Given this list of marker genes AFAP1L1, BPIFC, EPX, SGMS2, ABCG1 (NCBI Gene Id 9619), NRG1, RALB, TCN2, PLCG2, TET2, PELI2, ERO1B, GZMH, TTPA, LAPTM5 (NCBI Gene Id 7805), RAB11FIP5, NAV2, RAB27B, ARID5A, HPGD, DEPP1 (DEPP autophagy regulator 1), GFI1, EMP1, IL21R, TIFAB, MYO7A, HP, PRG3, F2RL3, CCDC125, SLC16A9, GPR15LG, SEPTIN6, CEMIP2, OLR1, S100A11, UNC93B1, STOX2, SLC7A6, TF, PKD1L3, TMEM141, C17orf50, GBX2, GOPC, MS4A3, ELANE, MAP3K15, VPREB3, FCGR2A, FFAR2, STARD8, TLR12P, CD48, P2RX7, CUEDC1, TCEA2, TEK, TMEM144, CLEC5A, PLD4, SUN2, CXCR6, CEBPE, CPNE3, SLC32A1, GCHFR, MCUB, PRODH, LDHB, RNASE2, ATRNL1, HSD17B1, ARMCX4 (armadillo repeat containing X-linked 4), MTF2, ENDOU, ELOVL7, F10, CASP1, KLHL5, TMEM119, VAT1, SPNS3, C11orf54, VSIG10L, SLC35B4, NKG7, DUSP2, SOX13, LBP, SERPINA3, LPGAT1, FNBP1L, SH3TC1, TFEC, P2RY14, TM6SF1, POGLUT3, TREM1, GSTM1, MISP, ESAM, VILL, EEPD1, ATP13A2, SLC24A5, GAS7, HIVEP3, GGTA1, DRAM1, LCP1, LRP12, TMEM53, EHD3, PLEK2, SLPI, F13A1, MGAM, EGLN3, UACA, TRIM45 (NCBI Gene Id 80263), TTC39C, SLA2, TSLP, PPP1R14A, BEX1, F2RL2, ASS1, GET1, RASGRP2, CDIN1, RHOBTB1, PARD3B, BACE1, ATP10A, ANXA5, SLAMF1, TMOD1, RNF180, MOGAT2, SCAMP5, ANK3, B3GNT8, ADGRG3, CSRNP1, EIF4EBP2, MEFV, PGAM1, ARHGDIB, CDA, GRPEL2 (NCBI Gene Id 134266), TCIRG1, SLCO3A1, CXXC4, SERPINB1, IDH1, NEMP1, GYS1 (glycogen synthase 1), NOTCH3, THADA, GADD45B, GSTM5, MFSD13A, KLKB1, PRG2, CEROX1, CFAP57, APPL2, STING1 (stimulator of interferon response cGAMP interactor 1, NCBI Gene Id 340061), GPR160, GFRA1, KRT18, UPK3BL1, GALK2, PPBP, PHF21A, WLS, DOCK9, NPL, PLPPR3, SPTAN1, C1R, NCF2, ABCD2 (NCBI Gene Id 225), SERPINB2, CHD7, CABLES1, KLF8 (NCBI Gene Id 11279), CLEC12A, PTPRJ, PPM1K, FLT1, CHD9, EVI2B, RAB44, PTGS1, PPFIBP2, CLDN15, ZXDC, SLC4A8, MAN1C1, DNTT, ADSS1, HPS3, PPIA, GCA, NCF4, EBF1, ATP8B4, NEK6, MCTP1, LTB4R, ARHGEF6, OR2A14, HVCN1, KCNIP3, VPREB1, RIN3, CCM2L, PXYLP1, LDLRAD3, SLCO4A1, ZC2HC1A, PRTN3, SPI1, CD300LG, CD93, UCN, SNX24, CD34, SOCS2, TNFRSF12A, MTA3, GMFG, RHOB, APP, CLEC4D, IRF6, HPSE, CRACR2B, H6PD, PARP8, CX3CR1, TAF5L, FABP5, IKBKE, KLRB1, HSD11B1, PTGER2, ARHGEF3, ERN1 (endoplasmic reticulum to nucleus signaling 1), RAB31, ALOX5AP, B4GALNT4, UBASH3B, TMEM38B, RALGPS2 (Ral GEF with PH domain and SH3 binding motif 2), NIM1K, DSTN, HK3, RASSF8 (Ras association domain family member 8), RAB27A, FNDC3B, MAST4 (NCBI Gene Id 375449), GPR65, FCGR2B, THNSL2, GPT2, ACOD1, NRG4, MDGA1, CLEC10A, KALRN, CDK5R1, PDE2A, GSTT3P, ADGRL4, PPP1R3B, PIK3IP1, CCND2, TNFAIP8, SIGLEC5, CASK, LYZL2, IGSF6, KRT80, MYCT1, ID1, RHOQ, PAM, KRT7, NOSTRIN, IL5RA, LGR5, SMYD4, CTF1 (cardiotrophin 1), HOXB2, CTSG, MSANTD3, ITPKB, RSPH9, GRIA3 (glutamate ionotropic receptor AMPA type subunit 3), ANXA3, CTSC, CYTH4, PPIC, F2R, PRSS16, SLC45A4, SH3BGRL2, GMPR, MFNG, STOX1, ITIH5 (inter-alpha-trypsin inhibitor heavy chain 5), SLC28A2 (solute carrier family 28 member 2), SPTBN1, TLE6, ALPK1, GOLGA5, H2BC13, ALAS1, CELF2, PLEKHA1, CIDEB (cell death inducing DFFA like effector b), MGST2, PRSS57, TMEM150B, CXCR4, PRKCQ, EBI3, CYP2J2, RAG1, NR1H3, HNMT, ADAP1, PLEKHA2, DSG1, HES5, LMO1, ZNF235, TGFBI, RNASE3, ICA1, IGLL5, C1orf21, TPM4, CALR, TNFRSF1A, CCDC102A, RAMP1 (receptor activity modifying protein 1), FBP1, B4GALT6, GPRC5A, CEBPB, BCR, ARHGEF2, NALCN, TMED3, HOMER3 (homer scaffold protein 3), SELPLG, TSC22D3, RBPMS, SPEF1, HLA-DQA2, DNMBP, C1orf54, PLOD3, CALML4, AATK (NCBI Gene Id 9625), CLEC4E, GPR171, ARL11, LDHC, AS3MT, GZMA, CXXC5, FKBP11, CRIPTO, SSTR2, HDC, TBXA2R (NCBI Gene Id 6915), PLPP2, SERPINB10, ITM2A, CST7, TESMIN (testis expressed metallothionein like protein), OR5AC1, here is a description of the gene set: Genes up-regulated in immature bone marrow progenitor cells upon knock out of CBFA2T3. While a number of DNA binding transcription factors have been identified that control hematopoietic cell fate decisions, only a limited number of transcriptional corepressors (e.g., the retinoblastoma protein and the nuclear hormone corepressor) have been linked to these functions. Here, we show that the transcriptional corepressor Mtg16 (myeloid translocation gene on chromosome 16), which is targeted by t(16;21) in acute myeloid leukemia, is required for hematopoietic progenitor cell fate decisions and for early progenitor cell proliferation. Inactivation of Mtg16 skewed early myeloid progenitor cells toward the granulocytic/macrophage lineage while reducing the numbers of megakaryocyte-erythroid progenitor cells. In addition, inactivation of Mtg16 impaired the rapid expansion of short-term stem cells, multipotent progenitor cells, and megakaryocyte-erythroid progenitor cells that is required under hematopoietic stress/emergency. This impairment appears to be a failure to proliferate rather than an induction of cell death, as expression of c-Myc, but not Bcl2, complemented the Mtg16(-/-) defect. Human Gene Set: CHYLA_CBFA2T3_TARGETS_UP from publication Chyla BJ, Moreno-Miralles I, Steapleton MA, Thompson MA, Bhaskara S, Engel M, Hiebert SW (PMID 18710942) species: Mus musculus